Given this list of marker genes CADM2, PARD3, ZFHX4, UBE2E2, IRS1, NHEJ1, STK24, CD69, SRP19, ZFP14, PABIR2, G3BP2, here is a description of the gene set: studied in species Homo sapiens from publication Chen Y, Wang X (PMID 31504780) Human Gene Set: MIR181C_3P Genes predicted to be targets of miRBase v22 microRNA hsa-miR-181c-3p in miRDB v6.0 with MirTarget v4 prediction scores > 80 (high confidence targets).